Given this list of marker genes F2r, Met, F2rl1, Hpgd, Stmn1, Vps54, Dgkq, Iqgap2, F2, Snca, Plek, F2rl2, F2rl3, here is a description of the gene set: studied in species Mus musculus Mouse Gene Set: GOBP_THROMBIN_ACTIVATED_RECEPTOR_SIGNALING_PATHWAY A G protein-coupled receptor signaling pathway initiated by thrombin binding to its receptor on the surface of a target cell, and ending with the regulation of a downstream cellular process.